The following is a description of a gene set: Human Gene Set: PID_CMYB_PATHWAY C-MYB transcription factor network from publication Schaefer CF, Anthony K, Krupa S, Buchoff J, Day M, Hannay T, Buetow KH (PMID 18832364) species: Homo sapiens, and this is the list of marker genes: CCNA1, CEBPD, HES1, UBE2I (ubiquitin conjugating enzyme E2 I), CD34, NLK, SND1, NRAS (NRAS proto-oncogene, GTPase), YEATS4, PAX5, ETS2, PTCRA, WNT1, GATA3, ADA, MYOD1, CEBPB, PPID, MYB, PIM1, MYF6, RAG2, ANPEP, SMARCA2 (SWI/SNF related, matrix associated, actin dependent regulator of chromatin, subfamily a, member 2), HRAS, GSTM1 (glutathione S-transferase mu 1), ZFPM1, CCNB1, PRTN3, SIN3A, PPP3CA, BCL2, PIAS3 (protein inhibitor of activated STAT 3), TFEC, IQGAP1, KITLG, LYZ, ETS1, CDK6, CLTA, SPI1, CREBBP, HSPA8, MAT2A, CSF1R (colony stimulating factor 1 receptor), GATA1 (GATA binding protein 1), COPA, MPO, CDKN2A, CASP6, SKI, SP1, KRAS, TOM1, TAB2, MAP3K7, PTGS2, CDKN1B, ADORA2B, EP300, KIT, MAF, MAD1L1, CCND1, LECT2, TRIM28, CDKN1A, CD4, ATP2B1, HIPK2, BIRC3, TAB1, CBX4, MCM4, ELANE (elastase, neutrophil expressed), CEBPA, COL1A2, MYC, H2AZ1, NCOR1, ZFHX3 (zinc finger homeobox 3), LEF1, SLC25A3, CA1